Given this list of marker genes Rab38, Sidt2, Ldlrap1, Ap1ar, Rab32, here is a description of the gene set: Binding to an AP-1 adaptor complex. The AP-1 adaptor complex is a heterotetrameric AP-type membrane coat adaptor complex that consists of beta1, gamma, mu1 and sigma1 subunits and links clathrin to the membrane surface of a vesicle. In at least humans, the AP-1 complex can be heterogeneric due to the existence of multiple subunit isoforms encoded by different genes (gamma1 and gamma2, mu1A and mu1B, and sigma1A, sigma1B and sigma1C). Mouse Gene Set: GOMF_AP_1_ADAPTOR_COMPLEX_BINDING studied in species Mus musculus